Given this list of marker genes SCN4A, AK9, SQSTM1, CHRND, RTN2, LRP4, MYH7, LDB3, NEB, TTN, HINT1, AGRN, GNE, COL13A1, CHRNE, RAPSN, MUSK, CHRNB1, DOK7, CHRNA1, TIA1, here is a description of the gene set: studied in species Homo sapiens Weakness of long finger extensor muscles Human Gene Set: HP_WEAKNESS_OF_LONG_FINGER_EXTENSOR_MUSCLES